Given this list of marker genes FJX1, CD24, NPTXR (NCBI Gene Id 23467), TUBA1A, PRPF31, FAM200C, here is a description of the gene set: species: Homo sapiens Genes down-regulated 6 h after induction of HoxA5 expression in a breast cancer cell line. The homeobox gene HOXA5 encodes a transcription factor that has been shown to play important roles in embryogenesis, hematopoiesis, and tumorigenesis. In order to decipher downstream signaling pathways of HOXA5, we utilized oligonucleotide microarray analysis to identify genes that are differentially expressed in HOXA5-induced cells compared with uninduced cells. Comparative analysis of gene expression changes after 9 h of HOXA5 induction in Hs578T breast cancer cells identified genes whose expression was modulated at least 2-fold. Ten of these genes were also up-regulated by at least 2-fold at 6 h post-induction. The expression of all of these genes was confirmed by semiquantitative reverse transcription-PCR. Among these genes, which are most likely to be direct targets of HOXA5, we initiated an investigation into the pleiotrophin gene by first cloning its promoter. Transient transfection assays indicated that HOXA5 can specifically activate the pleiotrophin promoter. Promoter deletion, chromatin immunoprecipitation assay, and gel-shift assays were performed to show that HOXA5 can directly bind to one binding site on the pleiotrophin promoter. These data strongly suggest that microarray analysis can successfully identify many potential direct downstream genes of HOXA5. Further functional analysis of these targets will allow us to better understand the diverse functions of HOXA5 in embryonic development and tumorigenesis. from publication Chen H, Rubin E, Zhang H, Chung S, Jie CC, Garrett E, Biswal S, Sukumar S (PMID 15757903) Human Gene Set: CHEN_HOXA5_TARGETS_6HR_DN